Given this list of marker genes KRT10, GJB2, EPHB4, ATP2A2, GJB6, here is a description of the gene set: Human Gene Set: HP_COBBLESTONE_LIKE_HYPERKERATOSIS Cobblestone-like hyperkeratosis studied in species Homo sapiens The presence of verrucous, cobblestone-like papules and nodules in a region of skin that is said to have an appearance like that of cobblestones.